The following is a description of a gene set: Human Gene Set: GOBP_NEGATIVE_REGULATION_OF_PROTEIN_LOCALIZATION_TO_MEMBRANE species: Homo sapiens Any process that stops, prevents or reduces the frequency, rate or extent of protein localization to membrane., and this is the list of marker genes: WNK4, LRRC15, SFN, TMEM59, NUMB, CSK, LYPLAL1, PID1, TMED2, DAB2, GDI1, USP17L2, LZTFL1, PPP2R5A, ITGB1BP1 (NCBI Gene Id 9270), ABI3, PKDCC, DMTN, GRIPAP1 (NCBI Gene Id 84538), ANXA13, LYPD1, RSC1A1, BCL2L1, PPFIA1, MRAP2, MRAP, AP2M1, RHOQ, WNK3, PICALM, WNK1, TGFB1, FZD9, KCNE1, TMBIM1, GBP1, LYPLA1, CLTC, INPP5K